Given this list of marker genes Psma6, Psma5, Psmb7, Ep300, Cul1, Psmc5, Psmd7, Psma1, Psmb5, Psma4, Psmc3, Psmb4, Psmd13, Psma3, Psma2, Psmb6, Rps27a, Psmc2, Psmd1, Prdx1, Psmd6, Psmc1, Ubb, Psmc4 (NCBI Gene Id 23996), Psmd12, Psma7, Psmc6, here is a description of the gene set: electronically inferred by orthology from the curated human pathway This event has been computationally inferred from an event that has been demonstrated in another species.<p>The inference is based on the homology mapping from PANTHER. Briefly, reactions for which all involved PhysicalEntities (in input, output and catalyst) have a mapped orthologue/paralogue (for complexes at least 75% of components must have a mapping) are inferred to the other species. part of: KEAP1-NFE2L2 pathway studied in species Mus musculus Reactome Pathway: Nuclear events mediated by NFE2L2